Given this list of marker genes IGF2BP2, YTHDF3, YTHDC1, FMR1, HNRNPC, YTHDF2, HNRNPA2B1, IGF2BP1, IGF2BP3, RBM33, YTHDF1, YTHDC2, here is a description of the gene set: Human Gene Set: GOMF_N6_METHYLADENOSINE_CONTAINING_RNA_READER_ACTIVITY studied in species Homo sapiens A protein adaptor that recognizes and binds an RNA molecule modified by N6-methyladenosine (m6A), a modification present at internal sites of mRNAs and some non-coding RNAs.